Given this list of marker genes RNU6ATAC, RNVU1-17, RNVU1-1, RNVU1-15, RNVU1-7, RNVU1-8, PRPF39, WEE2-AS1, RNVU1-4, RNU11, TAF12-DT, RNVU1-6, RNVU1-3, RNVU1-19, RNVU1-14, RNVU1-2A, RNU1-4, SNRPC, RNU4ATAC, here is a description of the gene set: Binding to a pre-mRNA 5' splice site sequence. species: Homo sapiens Human Gene Set: GOMF_PRE_MRNA_5_SPLICE_SITE_BINDING